The following is a description of a gene set: species: Homo sapiens Systems vaccinology has emerged as an interdisciplinary field that combines systems wide measurements and network and predictive modeling applied to vaccinology. Here we used the systems vaccinology approach to study the molecular mechanisms underlying th Human Gene Set: GSE29618_LAIV_VS_TIV_FLU_VACCINE_DAY7_BCELL_UP Genes up-regulated in comparison of B cells from LAIV influenza vaccinee at day 7 post-vaccination versus those from TIV influenza vaccinee at day 7 post-vaccination. from publication Nakaya HI, Wrammert J, Lee EK, Racioppi L, Marie-Kunze S, Haining WN, Means AR, Kasturi SP, Khan N, Li GM, McCausland M, Kanchan V, Kokko KE, Li S, Elbein R, Mehta AK, Aderem A, Subbarao K, Ahmed R, Pulendran B (PMID 21743478), and this is the list of marker genes: MYOZ3, LIPE, GK2, CNIH3, ENPP3, DEFB4A, INSL4, MCOLN3, RBBP9, CD70, RUNX2, CDC6, SERPINB5, BCL10, SLC26A1, GABRP, TAF5, KLHL21, CD226, ZNF358, SLC28A2, TMEM255A, SPHK2, RGS6, SPICE1, IGFBP4, RS1, SPMAP2, S100B, BPNT1, CRAT, NLGN3, TRIM23, LRP8, CRELD1, KCNA10, CCDC103, DPYSL4, RNF144A, TCP11L1, RAD51, MAD2L1, H2AP, CYP3A7, UPK3B, TAS2R3, SLC25A38, ACKR2, RAB40AL, FAT4, B2M, IL37, NLRP2, NRG2, FOXJ1, TRAV8-3, PALB2, TFF3, THRA, TAF4, AQP4, PLXNA3 (plexin A3), NPC1L1 (NPC1 like intracellular cholesterol transporter 1), NNMT, IGLV4-60, LORICRIN, NR1H3, ZNF442 (zinc finger protein 442), RPL10P17, TEAD3, TRIM17, TRIM48, FEZF2, MATN4, KRT14, DBP, UTS2, CALML5, RMDN1, GPT, CYB5A, CRYGD (crystallin gamma D), CRTAC1, COPS7B, IL5, NT5E, SCAND2P, TRIM25, ELOVL6, PRL, MAPK13, PROC, DNASE1L3, ITIH3, CSPP1, DNAH6, F11, VPREB1, COL1A2, IFNA7, TAS2R9, N4BP3, SSX5, AOC1, ZNF80, KIF5C, BAIAP2, INTS7, NEU1, GPR18, SERPINA7, PLEKHH3, OPN1SW, FBXO4, RGS3, NDRG2, GRM2, IL36A, UMOD, TBC1D22B, GLP2R (glucagon like peptide 2 receptor), TTC28, KIAA0087, CLPS (NCBI Gene Id 1208), PRUNE2, ZNF365, HMGB3P30, PNMA2, CA10, SRBD1, CHST7 (NCBI Gene Id 56548), FAM204A, FZD4, RNF39, TLX1, NPHS1, SLC37A4, SLC4A4, TRPM1, LAMB3, BARX1, DUSP14, LMO3, TRIP10, RASSF7, ID4, OGN, THAP7, TBC1D30, HOXB2, GH2, TSKS, CES1P1, BRSK2, BMAL2, NUBPL, ZNF215, ZBTB3, DUOX1, VSNL1, FAAP100, HCFC2, CAV3 (caveolin 3), TMSB15B, GYG2, TPD52L1, ANKRD1, DNM1, BBC3, POF1B, RAD51D, DCXR, TEX12, SNRNP40, ATM, PTH1R (NCBI Gene Id 5745), H2AC17, GCLM, GPD2, CDHR5, ZBED2, IFFO1, NAP1L2, BDNF, NHEJ1, BAIAP2L2, ADGRF1, KRT3, NID2, BCL2L10, CD9, LRRTM4, PCDH12, GUCA1A, TENM1, SLURP1, FAM120C, ANKRD27